The following is a description of a gene set: part of: Metabolism of nitric oxide: NOS3 activation and regulation Reactome Pathway: NOSTRIN mediated eNOS trafficking studied in species Homo sapiens eNOS traffic inducer (NOSTRIN) is a novel 506-amino acid eNOS-interacting protein. Along with a decrease in eNOS activity, NOSTRIN causes translocation of eNOS from the plasma membrane to intracellular vesicular structures. NOSTRIN functions as an adaptor protein through homotrimerization and recruitment of eNOS, dynamin-2, and N-WASP to its SH3 domain. Studies indicated that NOSTRIN may facilitate vesicle fission and endocytosis of eNOS by coordinating the function of dynamin and N-WASP, which in turn, recruits the Arp2/3 complex, initiating actin filament polymerization. Overall, this process is thought to occur via caveolar endocytosis. <br><br><br><br>, and this is the list of marker genes: WASL, DNM2, NOS3, CAV1, NOSTRIN